Given this list of marker genes MTHFR, PRDX1, MMACHC, LMBRD1, CTH (NCBI Gene Id 63046), here is a description of the gene set: An increased concentration of cystathionine in the blood. Cystathioninemia studied in species Homo sapiens Human Gene Set: HP_CYSTATHIONINEMIA